The following is a description of a gene set: Comparisons of global gene-expression profiles revealed a greater distinction between CD4+ Treg cells and CD4+ conventional (Tconv) T cells residing in abdominal (epidydimal) fat versus in more standard locations such as the spleen, thymus and LN. Human Gene Set: GSE7852_TREG_VS_TCONV_LN_DN from publication Feuerer M, Herrero L, Cipolletta D, Naaz A, Wong J, Nayer A, Lee J, Goldfine AB, Benoist C, Shoelson S, Mathis D (PMID 19633656) Genes down-regulated in comparison of lymph node regulatory T cells versus lymph node conventional T cells. studied in species Homo sapiens, and this is the list of marker genes: TMEM9B, FNTB, ACSS2, GUCD1, SLC35E3, C1orf21, DNAJC6, HSPB9, ITPR1, RNF150, TMEM71, XKRX, ARL5B, LYST, EFCAB6, SMTNL2, GRAMD2B, TTC36, EHD3, ATP8B4, PDLIM4, SLC5A11, AP2A2, PAOX, DNTT, SLC26A11, APPL2, KCNK12, GPR179, GRIPAP1, SGSH, POMC, CAMKK2, ALS2CL, AMPD1, FOXN1, SLC16A10, DAP, RYR1, AMIGO2, CHD7, HSD3B2, METTL9 (methyltransferase 9, His-X-His N1(pi)-histidine), POLE2, ACP3, ITK, ITGB3, LYPD6B, SHLD1, CYP2S1, RFLNB, EXOC8, MBOAT1, MYO3A, PPT2, BCL2L14, GATD1, TDRP, ATP6V0A2, GABRP, TCF7, SPICE1, NFE2L2, TREM2, RGCC, BTLA, ENTPD5, STK26, IFITM10, LBP, KRT76, SELENOP, PIK3R5, CLIP1, GPSM2, WDR13, EMB, AP3B2, TGFBR3, FAM78A, MAX, ADCY6, CNN3, ELOVL7, PIK3IP1, APP, RNF32, L3MBTL3, CTSV (cathepsin V), TRIM40, AFP, MN1, DAPL1, RAMP3, CNGA1, LDLRAP1, EPB41L1, FAM234B, RAP2B, GGT1, MCTP2, SLC30A4, ADAMTS16, GPR146, SATB1, MAP7, TM7SF2, TTYH3, SPTBN1, GSN, IL17RA, ICAM2, F8A1 (NCBI Gene Id 8263), CDR2, MBOAT4, FOXK1, SNN, ADH1C, SEMA4F (ssemaphorin 4F), IL1RL2, PPIC, DENND2D, SCML4, PLXNA4, XIRP1, VIPR1, LDLR, IKZF1, EMID1, PSD3, PEX6, RGMB, TRIM36, CELF4, H2BC13, TEC, ARHGAP29, IGF2BP2, RASGRP2, CDPF1, TOM1, CRTAM, MAMDC4, PDE3B, TAGLN2 (transgelin 2), IBTK (NCBI Gene Id 25998), S1PR1, GTF2I (NCBI Gene Id 90875), SLC12A7, MYO10, MFSD6, CARS1, SMAP2, LRTM2, SETD4 (SET domain containing 4), SUSD1, SYNE1 (NCBI Gene Id 85448), DYRK2, KLHDC1, TSPYL4, G0S2, DUSP10, IL2, ACTN1 (NCBI Gene Id 87), NUMB, CSNK1E, TMIE, GNMT, MFHAS1, EPAS1, DMBT1, LSS, EEIG1, SGK1, LANCL3, PUS7L, WNT3A, HS3ST3B1 (NCBI Gene Id 9953), RAPGEF4, FOCAD, HECTD2, UBE2J1, CERS6, SLC16A5, KCP, MYSM1 (NCBI Gene Id 114803), ST3GAL1, ATP1B1, PARM1, THEMIS, SEMA4A, ABHD15, NTRK3, GABRR2, IFIT2, ATXN7L3B, KLRD1, ENC1, LRRC75B